Given this list of marker genes Smg7, Barhl1, Zbtb37, Cyb5r4, Myo15a, Thap1, Hmox2, Mapk8ip2, Fignl1, Scrt1, Srrm3, Tjp2, Neurod4, Gm26224, Caskin2, Glrx5, Gm22489, Cacng3, Rph3a, Agk, Ccdc150, Gas5, Gm22357, Asic3, Mrpl14, Gtf3c6, Tsen54, Fbll1 (NCBI Gene Id 237730), Mbtps2, Srsf1, Ino80dos, Glra1, Rcan2, Gm13254, Omg, Sinhcaf, Abr, Ino80d, Mir7b, here is a description of the gene set: from publication Yevshin I, Sharipov R, Kolmykov S, Kondrakhin Y, Kolpakov F (PMID 30445619) Mouse Gene Set: ZFP534_TARGET_GENES studied in species Mus musculus